Given this list of marker genes CD244, PTH, PLCG2, SYNJ1, INPP4A, AVPR1B, INPP5J, IP6K1, GALR2, SNCA, ADCYAP1R1, ITPKA, PRKG1, PTAFR, INPP5A, NTSR1, PLCB1, INPP5B, P2RY6, IP6K2, NUDT10, NUDT4, P2RY1, MINPP1, PLEK, IP6K3, LHCGR, IPPK, NUDT3, ITPKB, SCP2, ITPKC, GPER1, ITPK1, PTH1R, PPIP5K1, OCRL, INPP4B, PPIP5K2, NUDT4B, NUDT11, IPMK, here is a description of the gene set: studied in species Homo sapiens Human Gene Set: GOBP_INOSITOL_PHOSPHATE_METABOLIC_PROCESS The chemical reactions and pathways involving inositol phosphate, 1,2,3,4,5,6-cyclohexanehexol, with one or more phosphate groups attached.